The following is a description of a gene set: Genes having at least one occurrence of the motif RRCAGGTGNCV in the regions spanning 4 kb centered on their transcription starting sites. This matches the TCF3 transcription factor binding site V$E12_Q6 (v7.4 TRANSFAC). studied in species Homo sapiens Human Gene Set: E12_Q6, and this is the list of marker genes: GPD1, HR, TMEM178A, FCMR, IGF2, SIPA1, NUP88, NBL1, PSTPIP1, RPAIN, PLCB3, DLL3, PPP1R9B, RNF220, COQ10A, DNMT3A, ARID5A, SIM1, PLEC, GNAS, NEGR1, GATA2, CORO2A, CELF4, ALDH1A2, RAPGEF4, ARHGAP36, NTRK2, FGF11, SEMA3F, NOL4, PNPLA2, TNFRSF21, AGAP3, NFATC4, GRB2, KCNB1, NTRK3, IGFBP5, DALRD3, SPCS1, GFRA1, GRB7, FOXI1, GPD1L, GGN, CKM, PTPRJ, MFNG, NKAIN2, NR4A1, TNFSF13, CYP26A1, DSCAM, RUNX1, FUT8, SMAD3, KRAS, HOXB7, PPOX, FBLIM1, CNNM2, ANK2, SFTPC, WDR81, IFT20, HMGA1, SGMS1, PACSIN3, SLC23A2, ARHGEF38, TNNC2, MINK1, IGF2-AS, ADAMTSL2, CHST9, WNK2, CCDC88B, MANEAL, EGLN1, ANKRD2, ZNF205, ACTN3, BMP6, SASH1, SLC12A5, MYOM3, IGF2BP1, ZNF710, LRP10, CFL1, ANKRD39, SOST, PLAGL2, TEAD4, MYLK2, CHRDL1, ADAM12, HES6, LYSMD2, ATXN7L2, EYA3 (EYA transcriptional coactivator and phosphatase 3), SORCS2, TRIM23, KRT8, DEF6, KLHL13, ASB14, LINC01565, WFIKKN2, DOK7, INVS, SLC37A4, BICDL1, ARHGEF12, TGFB3, PKN1, DCLK2, NHLH1, SCG2, COL4A3, POU2F3, FGF8, WNT6, MTSS1, PCDH15, AP1S2, MAMSTR, CPZ, MEGF8, GFAP, DLL1, CA7, PTK2B, GJB2, NDUFAF3, ESRP2, NEURL1, SORT1, COL22A1, IRX6, LYPD1 (LY6/PLAUR domain containing 1), CADM1 (NCBI Gene Id 337934), HMGN2, LNX2, EPDR1, PIM2 (Pim-2 proto-oncogene, serine/threonine kinase), CCNJL, MAP7, RASSF2, CDH5, C1QC, MYOZ3, SYT4, ARL5B, DOC2A, COL4A4, TNFAIP1, RIN1, MTUS1, ODC1, CDH2, LARP1B, WDR20, AIG1, C1GALT1C1, CPA4, CCNL2 (NCBI Gene Id 9613), JADE1, GPM6B (NCBI Gene Id 2824), ARHGAP24, PEX10, RAB26, ANKRD13B, NPEPPS, MDGA1, ELMO1, POFUT1, TREX2, USP2, MYH14, KCNK12, KCNN3, ABLIM3, CHD5 (NCBI Gene Id 26139), TTC17, CORO2B, SERBP1, CXCL14, CAMK1D, WTAP, HNF1B, RALYL, TPM3, HSD11B2, ITGA6, HEYL, FAM53C, MIR22HG, FSCN2 (fascin actin-bundling protein 2, retinal), VWA2, MT3, LRP5, ENO3, PLEKHH3, ITGA2, AGO1, SELL, AP5B1, PLPPR1, SEC31B, LINC00683, CANX, RANGAP1, SPTB, NSG2, GPR37, OSR1, CALB1, CYRIA, CHRND, HIF3A, GDPD2, CAMK2A, UNC13B, ARVCF, ELOVL1, STC2, GIT1, MPPED2, C6orf15, HBEGF, GRIA1, FYN, LAMA5, RRAGC, ROBO3, DCAF1, JSRP1, SMTNL2, SSH2, BEST3, ST3GAL5, TAFA2, CALN1, ACAP1, ME3 (NCBI Gene Id 10873), SOX17, EXOC6, DMPK, NEDD4L, DNAJB5, UNC45B, WWC1, CRCT1, SLC24A3, IGSF8, CRELD1, RTN4RL2, POLR1D, PHACTR3, CCDC85B, PPARA, PRKAG2, ITGB4